Given this list of marker genes SIRT6, LIG1, MUTYH, HMGA2, NTHL1, XRCC4, ADPRS, FEN1, XRCC1, POLB, POLD1 (NCBI Gene Id 5424), USP47, NEIL2, UNG, XPA, RPA1, LIG4, RPA2, TDG, ERCC6, WRN, RPS3, RPA3, HUWE1, NEIL1, LIG3, OGG1, APEX1, POLL, HMGA1 (high mobility group AT-hook 1), PRMT6, PCNA, NEIL3, PARG, POLG, ERCC5, HMGB1, APEX2, PARP1, POLE, PARP2, MPG, FAM168A, MBD4, POLQ, PNKP, SMUG1 (NCBI Gene Id 23583), DNA2, here is a description of the gene set: Human Gene Set: GOBP_BASE_EXCISION_REPAIR In base excision repair, an altered base is removed by a DNA glycosylase enzyme, followed by excision of the resulting sugar phosphate. The small gap left in the DNA helix is filled in by the sequential action of DNA polymerase and DNA ligase. studied in species Homo sapiens